Given this list of marker genes Pla2g3, Tnfrsf11a, Edn1 (NCBI Gene Id 13614), Pla2g6, Ptges (NCBI Gene Id 80632), Pla2r1, P2rx7, P2ry2, Cyp4a10, Tnfsf11, Pla2g10, Cyp4a31, Cyp4a32, Mapk9, Sstr4, Oxt, Map2k6, Avpr1b, Il1a, Mif, Ntsr1, Pla2g4a, Il1b, Hrh3, here is a description of the gene set: Any process that activates or increases the frequency, rate or extent of the controlled release of an icosanoid from a cell. studied in species Mus musculus Mouse Gene Set: GOBP_POSITIVE_REGULATION_OF_ICOSANOID_SECRETION